Given this list of marker genes PYCARD, RELA, IL1B, NFKB1, CASP8, MALT1, here is a description of the gene set: CLEC7A/inflammasome pathway Human Gene Set: REACTOME_CLEC7A_INFLAMMASOME_PATHWAY species: Homo sapiens